Given this list of marker genes LRWD1, CD27, CBX6, CAMK2B, ID2, IFIH1, IL6ST, RAC2, ACTN1, FAS, IQGAP2, CD160, CD96, AGRN, CTSD, DTX1, CISH, TRAF1, RGCC, S100A10, AUH, MS4A6A, NR4A1, CD3E, RPS6KA1, CD5, ADGRG3, IL6R, JAK3, CCL5, H2AZ1, SGK1, ST3GAL4, SUGT1, CDC26, FLT3LG, KCNAB2 (NCBI Gene Id 8514), GALNT10, FASLG, ENTREP3, IL18R1, PBX2, ATP13A1, CTLA4, LPIN1, UNC45A, SPNS1, CYB5A, WBP1L, PSTPIP1, HACD3, MYO6, CDK2AP2, IFI27, HM13, TNFRSF4, B2M (beta-2-microglobulin), TUBA1A, RCAN3, WDSUB1, CD3G, BATF, IL7R, FYN, TENT5C, DGKA, PHPT1, RPL30, TCF7, TMEM38B, RANBP3, PSMB3, NDRG2, PSME1, FDPS (NCBI Gene Id 2224), HPCAL1, ITGB1, NRP1, DOCK5, GLO1, KLK8, VPS37B, KLRD1, S100A4, SELPLG, ATP6V1E1, FAM89B, HBA2, CD6, TMC6, SKI, ARL4C, SIT1, WASHC3, GAPDH, RPS3, SEMA4A, PLEC, PDCD1, NAV2, TNIP1, WDR83OS, TNFSF11, ABCB9, ATP11A, PRKCQ, PPP4C, MYB, SLCO3A1, STIM1 (NCBI Gene Id 6786), MRPL2, IGF2R, LDHB, NSG2, ZAP70 (zeta chain of T cell receptor associated protein kinase 70), SSBP2, PDGFRB, COQ9, CBR1, ABHD8, ADK, CTSW, IRF7, PAFAH2, FXYD5, RGS10, ESYT1, OTULINL, RANBP9, ZNRF1, ITGA6, RORA, PTPN13 (NCBI Gene Id 5783), LBP, PDLIM4, CST7, HOPX, LXN, DDHD2, PJA1, ANXA2, DAG1, ISYNA1, MLX, PITPNM1, PFKP, TEX264, ITM2A, RYK, DNTT, ANGPTL2, NOTCH1, ITM2C, ACVRL1, NANS, TNFRSF1B, UCK2, STMN1, XDH, TNFAIP8L1, IFIT1B, VPS26B, SOCS3, PRKCSH, ITGB7, SFMBT2, BZW2, GALNT2, NEFH, SH2D2A, S100A6, TNFRSF1A, KCNN4, ALYREF, ARHGAP9, CD9, ISG15, THY1, RBM42, EYA2, MEPCE, CLPB, RFLNB, CD28, B4GALNT1, CRTAM, CD3D, ANP32A, SETD4, NPM3, NBEAL2, RPS16 (NCBI Gene Id 6217), PLD3, CD247, CDC23, KLF7, NPC2, NAB2, SNX14, FDX1, here is a description of the gene set: Human Gene Set: GSE23568_ID3_TRANSDUCED_VS_ID3_KO_CD8_TCELL_UP Genes up-regulated in CD8 T cells: over-expressing ID3 versus ID3 knockout. Mouse CD8+ T cells affected by ID3 (Inhibitor of DNA binding 3) display patterns of gene expression suggesting enhanced persistance and survival. In this study, we identified genes differentially expressed between ID32a transduced and mock transduced, and ID32a knockout and wild type mouse CD8+ T cells. Most prominent functions of differentially expressed genes include DNA replication-associated repair, maintenance of chromosome stability and mitotic cell divison machinery. Overall, these data suggest that ID3 acts in favor of maintained survival in CD8+ mouse T cells. species: Homo sapiens from publication Ji Y, Pos Z, Rao M, Klebanoff CA, Yu Z, Sukumar M, Reger RN, Palmer DC, Borman ZA, Muranski P, Wang E, Schrump DS, Marincola FM, Restifo NP, Gattinoni L (PMID 22057288)